The following is a description of a gene set: from publication Cui A, Huang T, Li S, Ma A, Pérez JL, Sander C, Keskin DB, Wu CJ, Fraenkel E, Hacohen N (PMID 38057668) Cytokines mediate cell-cell communication in the immune system and represent important therapeutic targets. A myriad of studies have highlighted their central role in immune function, yet we lack a global view of the cellular responses of each immune cell type to each cytokine. To address this gap, the authors created the Immune Dictionary, a compendium of single-cell transcriptomic profiles of more than 17 immune cell types in response to each of 86 cytokines (>1,400 cytokine-cell type combinations) in mouse lymph nodes in vivo. A cytokine-centric view of the dictionary revealed that most cytokines induce highly cell-type-specific responses. For example, the inflammatory cytokine interleukin-1β induces distinct gene programmes in almost every cell type. A cell-type-centric view of the dictionary identified more than 66 cytokine-driven cellular polarization states across immune cell types, including previously uncharacterized states such as an interleukin-18-induced polyfunctional natural killer cell state. species: Mus musculus Genes positively differentially expressed in cell type: NK cell upon treatment with cytokine: IL-4 in mouse lymph nodes in vivo. Mouse Gene Set: CUI_NK_CELL_IL4_RESPONSE_UP, and this is the list of marker genes: Dars1, Ranbp1, Pebp1, Thumpd3, Mrps15, Ak2, Ebp, Apex1, Bzw1, Bysl, Mrpl52, Rif1, Nop16, Uchl3, U2af1, Sdf2l1, Tbc1d2b, Smarcc1, Hnrnpab, Plekhf2, Mrps6, Pals2, Exosc8, Impdh2, Xpot, Mthfd1l, Ndufab1, Suclg1, Nfil3 (nuclear factor, interleukin 3, regulated), F2r, Tubb4b, Snrnp200, Eprs1, Bax, Nsmce4a (NCBI Gene Id 67872), Stat4, Alg5, Rpp38, Cab39, Hspd1, Noc2l, Npm3, Mthfd1, Suclg2, Brf1, Mrpl19, Fkbp4, Imp4, Trgc4 (T cell receptor gamma, constant 4), St13, Chchd1, Slc35b4, Bcl2, Skic8, Kcnq1ot1 (KCNQ1 overlapping transcript 1), Bccip, Higd1a, Otulin, Eif1a, Shmt2, Gps1, Lyar, Nme1, Hadh, Cox5b, Psma3, Dnajc2, Xdh, Mat2a, Pus7, Smim7, Galk1, Syncrip (NCBI Gene Id 78260), Tuba4a, Clptm1l, Samm50 (SAMM50 sorting and assembly machinery component), Ncr1, Grwd1, Nop58, Ydjc, Nop2, Ruvbl1, Mrto4, Tomm5, Pdcd11, Ppp1r14b, Aatf, Mbd3, Ccdc88a, Wdr46, Adss1, Rrp1b, G3bp1, Pa2g4, Cyc1, Cct5, Tcea1, Nolc1, Ebna1bp2, Ndufa1, Pdia6, Lta4h, Timm10, Nip7, Strap, Atp5f1b, Gapvd1, Eif4ebp1, Hspa5, Sytl3, Ccdc86, Pgk1, Eif2s1, Eif3b, Rsl1d1, Hspbp1, Ndufb4, Ubl4a, Prkab1, Rpp14, Lgals3, Fubp1, Pole4, Eif5a, Bub3, Uck2, Gsr, Ppm1g, Znrd2 (zinc ribbon domain containing 2), Rbpj, Vcp, Tcerg1, Kif2a, Coa3, Pim3, Polr3d, Klhdc2, Acat1, Prdx1, Trmt112 (tRNA methyltransferase 11-2), Psma5, Gar1, Uqcrq, Baz1a, Tmed5, Tfam, Eif3i, Mif, Eif4e, Ppa1, Znhit6, Hnrnpu, Utp14a, Mrps24, Ruvbl2 (RuvB-like AAA ATPase 2), Snrnp27, Bcdin3d, Gnl3, Nudt5 (NCBI Gene Id 53893), Atp5mc1, Slco3a1, Nop56, Eno1, Gtpbp4, Polr2h, Ppif, Pwp1, Pcna, Mrpl23, Nars1, Fbl, Cacybp, Slc29a1, Pabpc4, Abhd11, Polr1g, Nudt3, Septin7, Srsf3, Nudc, Pnp, Ddx18, Snx3, Ctsz, Glrx5, Cebpz, Mrpl12, Sh3bp2, Zfp706, Gzma, Gcsh, Hint1, Ran (NCBI Gene Id 19384), Wdr83os, Cdca7l, Eef1e1, Exosc3 (exosome component 3), Ppig, Eif3l, Mphosph10, Timm50, Dctpp1, Mrps28, Pdrg1, Uqcrfs1, Sec11c, Tmem238, Cycs, Dkc1, Larp4, Txnl4a, Ddost, Hspa4, Ccdc186, Ogfr, Cad, Cdc37, Fdx1, Psma2, Dnajb11, Mak16, Snrpb, Ppp3cc, Golt1b, Gsto1, Cdk4, Timm44, Ctps1, Ptma, Wdr43, Pdia4 (NCBI Gene Id 57384), Eif4a1, Cyfip2, Srf, Mrpl2, Gstp1, Il2rb (interleukin 2 receptor, beta chain), Ftsj3, Phgdh, Zranb2, Cdk6, Ppid, Cnbp, Wiz, Csf2, Zfp280d, Usp50, Arhgap26, Guk1, Park7, Mpv17l2, Snrpd3, Mrps5, Yif1b, Krtcap2, Ddx39a, Ifng, Snap47, Cct7, Bzw2, Etf1, Selenon, Nifk, Rcc2, Serbp1, Tmub1, Purb, Pno1, Hikeshi, Erh, Ndufa12, Psmc4, Rcl1, Eomes, Gpatch4, Rexo2, Glipr2, Rrs1, Knop1, Mri1, Spen, Romo1, Emc6, Hdgf, Supt16 (SPT16, facilitates chromatin remodeling subunit), Pim2, Reep5, Mtap, Nes, Cct8, Smarca4 (SWI/SNF related, matrix associated, actin dependent regulator of chromatin, subfamily a, member 4), Rbm27, Snhg6, Timm9 (NCBI Gene Id 72642), Tpi1 (NCBI Gene Id 21991), Got2 (glutamatic-oxaloacetic transaminase 2, mitochondrial), Atp5pf, Rpn1, Denr, Calr (calreticulin), Taf1d, Prmt7, Exosc5, Srsf2, Mtdh, Psmb2, Atp5f1e, Txn2, Fam162a, Xbp1, Snrpd1, Uqcc2, Slc25a5, Set, Eif2a, Mrpl17, Hsp90ab1, H13, S100a1, Mrpl4, Cox6a1, Ube2d2a, Ola1, Nsun2, Snrpe, Inpp4b, Tfdp1, Mettl1, Mrpl3, Nop10, Nhp2, Rars1 (arginyl-tRNA synthetase 1), Endog, Sms, Uqcr11, Eif2s2, Adh5, Chsy1, Vars1, Mrpl54, Tmed9, Ddx27, Prmt1, Eif3g, Mgat2, Abi2, Ppia, Ldha, Mrpl36, Ndufa4, Cct2, Psmd13 (NCBI Gene Id 23997), Hnrnpdl, C1qbp, Utp18, Klrb1a, Nudcd2, Arf6, Prps1, Rbx1, Stk39, Syce2, Alyref2, Gtpbp6, Dnajc1, Mrps33, Dnajc21, Gabarapl2, Sod2, Ddx21, Pfn1, Rrp15, Rrp9, Api5, Banf1, Ncl, Tcof1, Farsb, Atad3a, Srsf9, Kmt5a, Psmb5, Tmed2, Farsa, Hspa9, Pitrm1, Zfp593, Nptn, Ndufs6 (NADH:ubiquinone oxidoreductase core subunit S6), Cct3, Arl1, Phb2, Metrnl, Med28 (NCBI Gene Id 66999), Sema4d, Srm, Lsm7, Snrpf, Phb1, Ctsa, Socs1, Slc39a6, Qtrt1, Pus1, Fkbp2, Ndufc1, Agpat5, Npm1, Isg20l2, Ifrd2 (NCBI Gene Id 67007), Mydgf (NCBI Gene Id 28106), Cox5a, Gars1, Rgs19, Timm8a1, Nol12, Cst7 (NCBI Gene Id 13011), Ndufa10, Ndufa7, Atic, Mrps21, Dcaf5, Ccdc85b, Hspe1, Mrpl42, Pole3